The following is a description of a gene set: Genes consistently and robustly repressed by estradiol in MCF7 cells (breast cancer); this reperession was prevented by fulvestrant. Activation of estrogen receptor alpha (ERalpha) results in both induction and repression of gene transcription; while mechanistic details of estrogen induction are well described, details of repression remain largely unknown. We characterized several ERalpha-repressed targets and examined in detail the mechanism for estrogen repression of Reprimo (RPRM), a cell cycle inhibitor. Estrogen repression of RPRM is rapid and robust and requires a tripartite interaction between ERalpha, histone deacetylase 7 (HDAC7), and FoxA1. HDAC7 is the critical HDAC needed for repression of RPRM; it can bind to ERalpha and represses ERalpha's transcriptional activity--this repression does not require HDAC7's deacetylase activity. We further show that the chromatin pioneer factor FoxA1, well known for its role in estrogen induction of genes, is recruited to the RPRM promoter, is necessary for repression of RPRM, and interacts with HDAC7. Like other FoxA1 recruitment sites, the RPRM promoter is characterized by H3K4me1/me2. Estrogen treatment causes decreases in H3K4me1/me2 and release of RNA polymerase II (Pol II) from the RPRM proximal promoter. Overall, these data implicate a novel role for HDAC7 and FoxA1 in estrogen repression of RPRM, a mechanism which could potentially be generalized to many more estrogen-repressed genes and hence be important in both normal physiology and pathological processes. studied in species Homo sapiens Human Gene Set: MALIK_REPRESSED_BY_ESTROGEN from publication Malik S, Jiang S, Garee JP, Verdin E, Lee AV, O'Malley BW, Zhang M, Belaguli NS, Oesterreich S (PMID 19917725), and this is the list of marker genes: BMP7 (NCBI Gene Id 655), RPRM, EFEMP1 (EGF containing fibulin extracellular matrix protein 1), CLDN4, CXCR4, KLF6, BIK, RAP1GAP, CERK, MXD4, MUC1, CDH3, NDRG1